Given this list of marker genes UBE2S, TMEM258, LRRC46, SP1, TTC41P, LYPD4, LINC02367, USP42, SEC61B (NCBI Gene Id 10952), SNHG8, AJUBA-DT, SRSF10, MRPS16, ZFP30, MYBL1, ZSCAN22 (NCBI Gene Id 7601), RPA3, CCDC66, ITFG2-AS1 (ITFG2 antisense RNA 1), LCORL, TNS2-AS1, MRPL33, CTDNEP1, ARHGAP5, MARCHF11, SAC3D1, COX17, PREPL, NOP2, TRIM59, ZNF561, ADAM2, GNL3, LNP1, UFSP1, FBXO34, PMS2, HEXB, TRIM50, SHE, RNU2-2P, COX4I1, KMT2E-AS1, SPAG17, GSTCD, SH3TC2-DT, ZNF683, FAM90A28P, SULT1A1, H2AZ2-DT, UCP2, FADS2, HSPA2, HNRNPA2B1, MEIOSIN, ZNF131, ISG20, COA3, ENSG00000268686, IFT74, SRSF3, MRPS27, ALDOA, RBM14-RBM4, REXO5, SYCP1, EMC1, LARP4, NECAP1, TMEM168, EID2, SNHG29, SDR39U1, MOV10, SLC52A3, STARD6, TMBIM4, ANKRD18A, THAP6, ZBED5-AS1, ANP32E, SP8, UBE2I, PLAAT5, KRT8 (keratin 8), TOMM40, BMP4, CENPC, CLDN7, RIMKLB, TLCD3B, LONRF3, RFX4, EIF4G2, ZNF781, NCAPG, PPIE, LPXN, BRMS1, ERI2, ABCF1, LRSAM1, EZH2, ZNF561-AS1 (ZNF561 antisense RNA 1 (head to head), NCBI Gene Id 284385), SGTB, POLG2, C18orf54, LDAH, MYG1, SNORD49B, MIR6821, RAD1, KBTBD2 (kelch repeat and BTB domain containing 2), ACY1, ILRUN-AS1, YWHAG, CNOT9, DGKA, CAPZA1, NDUFS8, JTB-DT, MTPAP, NBPF1, CENPM, JCAD, PXN-AS1, PTGES3, TMPOP2, VTRNA1-2, ZMAT1, IHO1, WDR74, HNRNPH3, TOB2, ATM, UBC, POLDIP3, DCAF16 (NCBI Gene Id 54876), CDK4, SNORD24, ZMPSTE24, SENP8, SPPL3, GOPC, H2AX, CBX3, CYCSP41, MRPL10, MIR584, GDAP2, LINC01794, CDKN1B, CSTF3-DT, MORC1, CROCCP2, EIF2B2, H2BC6, DEDD, RBM14, LDHAL6B, NUP155, TRIM59-IFT80, MBD1, LINC02475, ANAPC5, MLH3, ZMPSTE24-DT, MYCBP2, COQ8B, NACA, VPS41, NKIRAS1, UBE2Q2P1, CEP44, SNAPC3, SLC7A6OS (NCBI Gene Id 84138), HENMT1, C14orf119 (NCBI Gene Id 55017), SMIM15-AS1, RBM48, MARS1 (NCBI Gene Id 4141), ZNF224, STAT1, FAM201A, GTF3C2, MEMO1, LINC02610, NEU3, GTF3C2-AS2, MYADM, PPP1R18, ZFP91-CNTF, DCUN1D4, WARS2-AS1, ENPP3, LIG1, ATF7-NPFF, TESHL, MCPH1-AS1, SPATS2, HDAC7, CCDC115, TDRD10, CAMK2D, SNX8, DUSP18, ZBTB32, SYNGAP1, ETAA1, KIF9, CYP4X1, LZTS2, MYADM-AS1, ANKRD18CP, SMIM27, MPI, KRT18, ITFG2, RFX2, ANKRD13C-DT, TPM3, IFT74-AS1, POTEF, NRL, RN7SKP114, MED23, HADHA, PLAA, POLR2E, ENSG00000275765, AREL1, LETMD1, TNS2, FCF1, LINC01409, PHF5A, USP53, PPP1R12A-AS1, ANKRD7, POLR3B, DTWD1, POM121L2, CDC26, LEISA1, HNRNPA1, DEDD2, PBK, THAP5, NME1-NME2, ALYREF, SH3RF2, MED22, XNDC1N, TOMM70 (NCBI Gene Id 9868), MARCHF9, TMUB2, STAG3L5P, FBXO34-AS1, STT3A (NCBI Gene Id 8071), MIR5188, CENPF, PAN2, MIR200CHG, ANKRD19P, RAB11A, SNRPB, PTEN, NFIX, G3BP1, PDE4A, CCND2, ANKRD36BP2, RPL27A, STAG3L5P-PVRIG2P-PILRB, ZDHHC17, RPL15, EIF3B (NCBI Gene Id 8662), PMS1, PEX1, POLK (NCBI Gene Id 51426), CHD1, PTPN13, RMI1, POTEH, SNORA24 (small nucleolar RNA, H/ACA box 24), FEN1, C5orf58, CCNT1, PPP3CA, ST7L, SMARCA2, PABIR1, HOXD3, SLC25A35, DCAF12, LUC7L2, RPS6, AJUBA, LCLAT1, PNPLA8, C2CD3, TMEM143, FNTB, RAB5B, NPAT, LRR1, RGS9, MARCHF11-DT, BLOC1S2, FBXO8, SLC4A8, INTS12, MYL6, LINC01120, FXYD5, SYNGR4, LINC00904, PPP1R12A, HSP90AB1, TRMT11, NR2C2AP, SASS6, GPN3 (GPN-loop GTPase 3), BTBD10, CNNM2, HNRNPUL1, DMRTC2, H2AZ2, PPP1R2C, RPL12, MAZ (MYC associated zinc finger protein), ACIN1, EEF1AKMT3, RFWD3 (NCBI Gene Id 55159), RAD52 (NCBI Gene Id 5893), G3BP2, PPM1E, ENSG00000246308, MGAT4D (MGAT4 family member D), NME1, RPLP0, RNU2-17P, CIC, MRPL45P2, ALG2, HOXA10-AS, LINC00933, DHRS7B, TMTC2, HADHB, ATF7, CLDN4, DCAF11, WDR89, TFAP2A, ZSWIM9, WARS2, RPL7A, LINC02851, CSTF3, KRT18P55, MSL2, LCK, FAM114A2, RSBN1, C3orf85 (NCBI Gene Id 401081), ROCK1P1, TMEM184A, DDR1, INTS2, SNHG15, IMP4, PSRC1, SERF2, SPRED1, OR6R1P, USP5, ARL4D, CANX, PMEL, RNF121, PBRM1, RCHY1, MALAT1, MYL6B, AIMP2, ORMDL1, USP3, ANKRD13C, HNRNPK, ZFP91, KIFC1, SEH1L, ZNF768, GADD45B (growth arrest and DNA damage inducible beta), MTERF1, MIR3913-1 (NCBI Gene Id 100500903), CNTD1, TRMT13, CLOCK, ARHGDIG, H4C16, DPH6-DT, MYO9A, POP4, FMN1, COX20, DKKL1, SH3TC2, KSR2, INO80D-AS1, ANAPC11, BICRAL, KLHL22, LTA4H, MCRS1, MRPL42P1, MYO1E, PIWIL1, ERC1, NAV2, ASB16-AS1, ERCC5, LINC01838, JTB, HMGB3P22, PAPOLA-DT, AMN, LINC00654, SCAND3, DDX50, REXO2, RPS29, CCDC97, PKM, HNRNPAB (heterogeneous nuclear ribonucleoprotein A/B), PFDN5, KASH5, LINC02983, ZBED5, FAM216A, SNRNP70, PRRC2A, GRB2, SLC4A8-AS1 (NCBI Gene Id 107984508), TMEM248, TINAGL1, PGD, LINC01206, GOSR1, HYLS1, CALN1, ELP5 (NCBI Gene Id 23587), CBLL1 (NCBI Gene Id 79872), CNGA4, CFTR, CDCA3, LINC02965, RBM34, UBAP2, HSPA2-AS1, CLXN, POP5, STT3B, GDPD1, BRIX1, FAM227B, QSOX1, ARRDC1, ZKSCAN3, CERT1, PAPOLA, AGPAT5, ESR2, MICOS13, ZNF526, LINC01801, CCT2, LINC02087 (NCBI Gene Id 101928567), FKBP6, PRPF4, here is a description of the gene set: studied in species Homo sapiens Genes containing one or more binding sites for (MYBL1) in their promoter regions (TSS -1000,+100 bp) as identified by GTRD version 20.06 ChIP-seq harmonization. Human Gene Set: MYBL1_TARGET_GENES from publication Yevshin I, Sharipov R, Kolmykov S, Kondrakhin Y, Kolpakov F (PMID 30445619)